Given this list of marker genes Sema3a, Gm5141, Klra9, Gm14325, Fmo9, Asph, Zfp967, Zfp811, Mtmr4, Prickle2, Plb1, Lta, Zfp973, Lamc1, Rap1b, Gm14308, Rest, Ttc33, Zeb2, C1s2, Psd3, Daam1, 2210418O10Rik, Zfp936, Rbm41, Pou3f2, Cnot7, Nos1, Mef2d, Zfp951, Boc, Fzd5, Cyb5r3, Ogt, Snph, Ret, Klra3, Lrp4, Zfp960, Gm2026, Bcas3, Gm6712, Dpysl2 (NCBI Gene Id 12934), Gm20939, Zfp781b, Nek9, Smpdl3b, Czib, Mthfr, Kcnn3, Cmtm6, Zfp120, Kcnt2, Dclk1, Dlg2, Zfp965, Gm14322, Zfp930, EU599041, Zfp975, Gdf6, Kmt2a, Ralbp1, Gtf3c4, Inka2, Klf14, Zfp869, Cmtr2, Zfp971, Arpin, Slc4a8, Cacng6, Lrit1, Riok3, Cplx2 (NCBI Gene Id 12890), Klra8, Eva1a, Rtn4rl1 (reticulon 4 receptor-like 1), Epc2 (NCBI Gene Id 51924), Sugt1, Gm14326, Tardbp, Creb3l3, Galnt6, Zfp937, Gm10778, Ube2r2, Hrh1, Zfp1008, Zfp87, Naa30, Homez, Gm14296, Dynlt5, Zfp976, Tgfb1i1 (NCBI Gene Id 21804), Rreb1, Ppargc1a, Vps13c, Sertad1, Mmp25, Alx4, Marchf9, 2010315B03Rik, Rnf216, Nhsl3, Cdh2, Exo1, Dscaml1, Ddo, Zfp935, Camk2g, Gm6710, Aebp2, Prkca, Arhgef7, Zbtb40, Prok2, Wdr37, Dio2, Pabir1, Tmem178b, Zfp275, Bltp3a, Zfp738, Acoxl, Gprc5b, Itih5, Plxna1, Zfp1009, Cbl, Zfp729a, Zfp708, Zfp970, Nhsl2, Gabrb2, Ppp2r1a, Irs1, Fas, Mapt, Tmod2, Zfp493, Tmem9, Slc7a3, Gm14391, Plxna2, Ror1, Med1, Zfp97, Agap1, Cd3g, here is a description of the gene set: from publication Chen Y, Wang X (PMID 31504780) Genes predicted to be targets of miRBase v22 microRNA mmu_miR_7649_3p in miRDB v6.0 with MirTarget v4 prediction scores > 80 (high confidence targets). Mouse Gene Set: MIR_7649_3P studied in species Mus musculus